Given this list of marker genes Numa1 (NCBI Gene Id 94347), Dhx36, Kalrn (kalirin, RhoGEF kinase), Ncs1, Ago2, Gdpd5, Shank2, Homer2 (homer scaffolding protein 2), Grik5, Camk2b, Lrrk2, Slc4a8, Atp5mc1, Usp8, Ctsl, Snx18, Palm, Rac3, Plec, Avp, Cyp46a1, Epha7, Kcnn3, Aqp1, Epha10, Aif1, Itpr3, Scn8a, Slc7a10, Apc, Atxn1l, Casr, Nlgn3, Prkcg, Cd200l2, Sh3glb1, Htr1b, Fmr1, Capn2, Pclo, Clstn2, Ppp1r9b, Ccr2, Ube2i, Tmem266, Trpc2, Bptf, Scn1a, Samd4, Crh, Syngap1 (synaptic Ras GTPase activating protein 1 homolog (rat)), Snap91, Htr1f, Cfl1, Inpp5j, Mapk8ip2, Bmpr1a, Pnmt, Dbh, Mtmr2, Npy, Adcy4, Sri, Hdac1, Phaf1, Epha3, Scgn, Kif5c, Lmtk2 (lemur tyrosine kinase 2), Jph4, Apod, Kcnma1, Mark3, Hcfc1, Ccl2, Palld (palladin, cytoskeletal associated protein), Dhodh, Ephb2, Ndufs7, Arhgef2, Dab2ip (NCBI Gene Id 98996), Psen2, Snap47, Adnp, Fez1, Ptk2b, Kcnip3, Ptges3, Cd3e, Stx3, Ppargc1a, Prkcz, Ptprn, Calb1, Wdfy3, Rrm1, Rgs14, App, Nts, Ncoa2, Crhr2, Cask, Met, Slc30a1, Arhgap32, Caprin1, Npcd, Lrp8, Trf, Cpne6, Cadm2, Mcrs1, Pde2a, Ndel1, Gper1, Cnn3, Kcnc3, Serpinf1, Esr2, Ddn, Txnrd1, Cacng2, Rbm8a2, Thy1, Washc5, Cck, Shisa7, Erbb3, Bglap (bone gamma carboxyglutamate protein), Ppp1r1b, Ptpn5, Strn4, Dlg3, Fcgr2b, Pard3, Ddc, Homer1, Ldlr, Ireb2, Bmpr2, Ush2a, Strn, Ntf3, Adcy10, Srsf10, Taok2, Glra1 (glycine receptor, alpha 1 subunit), Grik4, Olfm1, Atf4, Sorcs2, Scn11a, Hnrnpk, Gng13, Rplp0, Siah2, Ncdn, Gabra3, Cacna1e, Itgb1, Ank3, Zwint, Sarm1, Kremen1, Rapgef3, Exoc4, Ntrk2, Abitram, Scn3a, Kng1, Rab1a, Ltbp1, Bmpr1b, Snap25, Map2k1, Eif4a3, Cftr, Chrm2, Crhr1, Acsl4, Rac1, Entpd1, Klc1, Src, Plxdc1 (NCBI Gene Id 72324), Mbp, Ppp1r2, Cntnap2, Calcr, Kifap3, Rab8a, Nlgn4l, Ica1, Mob4, Cpeb3, Slc6a6, Dnm3, Th, Rnf112, Cyp19a1, Cald1, Ttll7, Chrm4, Fzd3, Katna1, Hsp90ab1, Epha6 (Eph receptor A6), Dlg4, Psen1, Tmprss11c, Slit2, Arhgef15, Vgf, Prex1, Gabrg1, Smn1, Atp13a2, Chrna4, Cacng7, Hrh3, Txnrd2, Agap2, Sptbn2, Kcnq1, Grin3a, Ppp1r9a, Ckb, Rasgrf1, Hcn4, Calca, Pjvk, Hnrnpab, Kncn, Nr3c1, Tacr3, Ntrk1, Mul1, Enpp1, Sumo1, Syncrip, Hspa5, Fas, Dtnbp1, Kcnc1, Myo5b, Hrh1, Pde10a, Unc5a, Cx3cr1, Pde4b, Tmem151a, Tgfb1, Ptger3, Abi3bp, Fgf13, Prkn, Timp2, Star (steroidogenic acute regulatory protein), Asic2, Sez6 (NCBI Gene Id 20370), Gnaq, Ptger4, Tbx21, Adam11, Ngfr, Dlg1, Flnb, Fzd5, Apoe, Mark1, Rab2a, Ntsr2, Alox5, Npff, Atp7a, Slc32a1 (solute carrier family 32 (GABA vesicular transporter), member 1), Gnat1, Nqo1, Ptchd1, Ppp1ca (protein phosphatase 1 catalytic subunit alpha), Bdnf, Slc6a2, Slc1a2, Comt, Lynx1, Mapk8ip3, Drd4, Grm5, Cacna1c, Stx4a, Kcnk2, Eef1a2, Zdhhc5, Negr1, Cpeb1, Klhl20, Rab3ip, Reg1, Sorl1, Ifngr1 (NCBI Gene Id 15979), Gabre, Sharpin, Apba2, mt-Nd1, Slc9a6, Efna2, Gad2, Resp18, Oprm1, Kpna1, G3bp1, Endog, Il6st, Ptch1, Gnb3, Neo1, Rin1, Dagla, Lrfn3, Gal, Gnas, Kcnq3, Cnga4, Dynlt1f, Kcna2, Adcyap1, N4bp3, Slc17a8, Ptprf, Ada, Adcy8, Slc5a7, Elovl5, Cdk5, Nell2, Prkca, Trak2, Csf1r, Ephb6, Atxn10, Grid2ip, Eif4a3l2, Kcnc4, Chat, Adcy9, Atp2b2, Rheb, Gabbr1, Cd2ap, Trim9, Map1a, Cdc42, Srebf2, Hnrnpu, Myo1d, Rabgef1, Fbxw11, Apob, Baiap2, Gigyf2, Cacng3 (calcium channel, voltage-dependent, gamma subunit 3), Dcp1a, Mink1, Rtn4, Gabra2, Sos1, Smo, Ilk, Add1, Frmpd4, Nrdc, Kcnd2, Ppp1cc, Prkaa2, Kcnh1, Actn1, Adam21, Bsn, Arhgap33, Ermn, Clstn1, Spg11, Itsn1, Fus, Kif1a, Rogdi, Rptor, P2rx3, Tpx2, Gad1, Lrp4, Gipc1, Uhmk1, Abi3, Kcnj11, Fyn, Cacna1f, Cnga2, Tsc22d4, Wdr47, Cpeb4, Osbp2, Enc1, Map2, Epha5 (Eph receptor A5), Snph, Casp6 (caspase 6), Kcnn4, Git1, Canx, Dpysl5, Septin14, Gfra1, Nrsn1, Sptbn4, Asap1, Gpm6a, Ascl1, Srd5a1, Opa1, Upf3b, Slc2a3, Cplx1, Gabra6, Arhgef7, Kirrel1, Cabp1, Syn1, Got2, Tmem50a, Vmn2r1, Serpine2, Cib1, Whrn, Klhl24, S100b, Zpr1, Kcnb1, Creb3, Drp2, 4930544G11Rik, Cacna1a, Ptpro, Picalm, Penk, Map6, Ngf, Camk2n1, Grik2, Map1b, Gabrb1, Pcmt1, Gabra4, Grin3b, Glrx3, Dync1h1, Vstm5, C4b, Malat1, Nppa, Ift52, Vps13a, Kcnj4, Dlgap4, Rit2, Ppp5c, Nf1, Slc9a5, Arg1, Fev, Cnnm4, Ache, Map1lc3b, Gnb1, Vti1b, Chl1, Hdac6, Azin2, Slc38a2, Iqschfp, P2rx2, Kif3b, Mapk8ip1, Hpn, Kif5a, Adgrb1 (NCBI Gene Id 97994), Pvalb, Pias3, Slc8a2, Trpc5, Ppt1, Slc8a3, Ppfia1, Septin4, Ctla2a, Rtn1, Fkbp4, Kndc1, Ctnnd2, Rps6-ps4, Ift20, Sez6l, Kcna4, Ybx1, Ubxn2a, Cacna1d, Shisa9, Evx1, Septin7, Gata3un (Gata3 upstream neighbor), Abhd13, Dynlt1a, Nsg1, Naip1, Lrp1, Igsf9, Lhfpl4, Cfh (NCBI Gene Id 192290), Itga4, Hcn1, Eef2k, Tiam1, Gchfr, Kcna1, Begain, Atp6ap2, Tanc1, Tnk2, P2rx7, L1cam, Anxa5, Ror2, Pebp1, Rgs10, Gnao1, Ccr4, Kcnk1, Pycard, Pdgfb, Htr4, Cacng8, Ncf1, Farp1, Hnrnpa2b1, Pde9a, Adra2a, Trpm2 (NCBI Gene Id 97643), Omp, Cpe, Cobl, Chrna10, Arhgap44, P2rx6, Tgfb2, Hspb1, Htr6, Acan, Pals1, Trpm1, Rtn4rl2 (reticulon 4 receptor-like 2), Fubp3, Gap43, Dnajb1, Hrh4, Htr5b, Prkar2b, Fbxo2, Ptprs, Kif17, Hsp90aa1, Kcnk9, Mrgpra3, Rbfox3, Nin (ninein), Slc38a1, Kcnj14, Dynlt1b, Rangap1, Adcy1, Slc6a1, Naip6, Inpp5f, Txn1, Ephb1, Pdyn, Uri1, Rps6, Pam, Homer3, Adcy2, Cst3, Insr, Nlgn2, Asic1, Snca, Grin2b, Dvl1, Ppp2r1a, Kif2a, Lrp6, Elk1, Slc12a2, Nsf, Cdk5r1, Acvrl1, Bglap2, Vip, Arrb2, Chrm5, Adrb2, Eif5a, Syap1, Kcnc2, Astn1, Clstn3 (calsyntenin 3), Dicer1, Ifng, Amigo1, Mtnr1a, Cntf, Lsm1 (LSM1 homolog, mRNA degradation associated), Abl2, Rtn4rl1, Nectin3, Trim3, Fxr1, Plcb4, Optn, Cnr2, Gopc, Pmm1, Grk3, Grik3, Ret, Grm2, Kcnab1, Cntn2, Klhl17, Unc80, Epha8, Fat3 (NCBI Gene Id 382129), Ckap5, Gabrg3, Arpc2, Btd, Trpm4, Nos1, Erbb2, Brinp3, Adra2c, Ang, Zfp804a, Dner, Rgs11, Dlg2, Glra3, Rtn4r, Ptprz1, Grip1, Pcsk5, Kif3c, Skor1, Kcnd1, Cyp17a1, Mmp3, Psd2, Rack1, Grin1, Kirrel3, Tacr1, Dab1, Gabrb2, Adora3, Sod1, Mlph, Dip2b (NCBI Gene Id 239667), Nr1d1, Trpv1, Pmm2, Mylk2, Zc4h2, Aurka, Crtc1, Ager, Ass1, Gip (NCBI Gene Id 14607), Fabp7, Cd22, Cpne5, Neurog1, Eno2, Igf2bp1, Aatk, Cnga3, Arc, Aplp2, Kcnd3, Usp33, Ophn1, Trpm7, Efhc1, Sv2a, Pde1b, Gpr37, Necab2, Atoh7, Dgki, Ercc8 (NCBI Gene Id 77046), Grk2, Rgs8, Afdn, Rapgef2, Brinp2, Rin3, Nlgn1, Lrp2, Epha4, Nrsn2, Astn2 (astrotactin 2), Slitrk2, Slc12a5, Gabra5, Kcnj2, Ubb, Zdhhc12, Scn1b, Inha, Mdga1, Pnoc, Dpp6, Dlgap2, Igsf9b, Ngb, Flrt1, Hnrnpr, Dip2a, Tmprss5, Cit, Drd2, Htr1a, Kif3a, Cx3cl1, Ctnnb1, Lama2, Rph3a, Inpp5a, Max, Fscn1, Shh, Rbm8a, Kcnip1, Becn1, Cacna1h (calcium channel, voltage-dependent, T type, alpha 1H subunit), Mapt, Dbnl, Nrp1, Slc25a27, Rara, Sfpq, Shank3, Atp1a3, Arrb1, Syndig1, Copa, Pde1a, Dynlt1c, Reln, Htr1d, Bnip3, Sema4f, Klhl14, Ptk2, Cadm1, Tanc2, Rab27a, Rgs12, Anks1b, Gabrg2, Pura, Brs3, Sipa1l1, Gpc1, Synpo, Jam2, Tnf, Hpca, Sh3gl2 (SH3-domain GRB2-like 2), Pgr, Acot7, Esr1, Nmnat3, Kcnn1, P2ry1, Rcvrn, Psmc2, Cyp11a1, Chrm3, Drd1, Aqp11, Ngdn, Efnb2, Glrx, Fzd4, Kcnj12, Mark4, Mgat5, Htr3b, Tmem108, Bag2, Mtor, Grm8, Pum2, Marcks, Rgs7bp, Oprd1, Kng2, Slc3a2, Cygb, Htr3a, Eif4b, Igf1r, Apba1, Slc8a1, Hspa8, Cacng4, Apbb1, Capzb, Cacna1g (NCBI Gene Id 12291), Nectin1 (nectin cell adhesion molecule 1), Pdlim4, Shroom2, Mpl, Prr7, Igf1, C9orf72 (C9orf72, member of C9orf72-SMCR8 complex), Mapk8, Uchl1, Ccn3, Eif4a3l1, Agfg1 (NCBI Gene Id 98611), Wfs1, Apba3, Dmd, Ppp3ca, P2rx4, Slc1a1, Abhd17b, Kcnip4, Tpbg, Shisa6, Csnk1e, Septin11, Mapk1, Pex5l, Zc3h14, Shtn1, Adam10, Napepld, Trak1, Ncam1, Lrit1, Chrna3, Tmprss3, Robo1, Slc18a2, Agrp, Ric3, Gabra1, Ttbk1, Prnp, Crhbp, Shank1, Mt3, Pde1c (phosphodiesterase 1C), Opn4, Polr2m, Tmem222, Gpr179, Myo6, Itga8, Nsg2, Tmem185a, Nucb2, Brinp1, Kif1b, Hcn2 (hyperpolarization-activated, cyclic nucleotide-gated K+ 2), Dlgap3, Grm1, Dyrk1a, Clip2, Glra4, Cpt1c, Cdkl5, Cttnbp2, Hcn3, Gphn, Grm7, Cyp11b2, Wls, Dock10, Lzts3 (NCBI Gene Id 278961), Cnksr2, Mpdz, Adora2a, Map1s, Sema3a, Psd, Grk4, Crcp, Palmd, Cplx2, Magee1, Snx1, Akap12, Zfp385a, Akap9, Ntsr1, Lrrc4, Naip2, Magohb, Tiam2, Asl, Grip2, Ndfip1, Dmwd, Ntf5, Sez6l2, Slc1a3, Rgs7, Kdr, Prss12, Plk3, Kif21b, Glrx5, Vps16, Trhr2, Plk2, Camk2d, Srr, Syt5, Map2k4, Lrit3, Sncb, Cryab, Cttn, Kcnj6, Katnb1, Ckmt1, Lamp1, Gnrh1, Clu, Bace1, Xrn1, Tubb4a, Cd200l1, Ero1a, Strn3, Rpsa, Pcsk2, Calb2 (calbindin 2), Rap1gap, Cyfip1 (NCBI Gene Id 29878), Flna, Crmp1, Oprk1, Gjc2, Myo10, Gabrd, Ighmbp2, Mark2, Kcnip2, Abhd17a, Myh10, Cnih3, Htr7, Bglap3, Cd40, Alcam, Impa1, Lgi1, Shisa8, Tsc2, Piezo2, Stat1, Ptbp2, Pi4k2a, Ulk1, Arf4, Grm3, Gng3, Maf1, Gna12, Myl7, Fxr2, Pten, Cnih2, Bcr, Srcin1, Htr2b, Dixdc1, Erbb4, Trp63, Chrna5, Erc2, Cript, Golga2, Grik1 (glutamate receptor, ionotropic, kainate 1), Neurl1a, Kif1c, Pcdh8, Mme, Hap1, Gria4, Boc, Bin1, Zmynd8, Gdi1, Grid1, Ift57, Rab5a, Samd14, Atp2b1, Pdpk1, Ptpn6, Klhl1, Stau2, Rufy3, Khsrp, Nsmf, Cad, Sdc2, Stmn2, Kcnn2, Slc22a3, Mapk10, Hrh2, Brd1, Zfyve27, Kcne3, Dctn1, Tpgs1 (NCBI Gene Id 216149), Casc3, Smurf1, Tubb3, Tmem100, Il6ra, Lamp5 (lysosomal-associated membrane protein family, member 5), Rps3, Cyba, Prrt2, Prph, Gria3, Glul, Ccr1, Tenm2, Ucn, Lypd6, Ghrh, Myo5a, Frmd7, Anxa3, Numb, Grm4, Gsk3b, Dtnb (NCBI Gene Id 13528), Top1, Rhoa, Nrxn1, Nrg1, Nefm, Itpka, Abhd12, Ghr, Cntnap4, Slc4a10, Nptn, Grid2, Akap5, Itpr1, Sst, Nrgn, Pcsk1, Dennd1a, Pafah1b1, Grm6, Hip1r, Chrna7, Ctnnd1, Maob, Chrm1, Gria2 (NCBI Gene Id 14800), Glrx2, Dscam, Als2, Espn, Pard6a (par-6 family cell polarity regulator alpha), Snx14, Flot2, Glrb, Htr2c, Trpm5, Syt4, Lrrc7, Slc6a3 (solute carrier family 6 (neurotransmitter transporter, dopamine), member 3), Htt, Lnpep, Mapk9, Grin2a, Arfgef2, Kif21a (NCBI Gene Id 16564), Dbn1, Ccng1, Atp1a2, Tnn, Cntnap3, Hdc, Htr5a, Txn2, Ppfia2, Casp4, Srd5a2, Sorbs2 (NCBI Gene Id 77324), Srgap2, Ar, Pabpc1, Cybb, Pak1, Tgfb3, Unc5c, Syt7, Pawr, Slc38a7, Ubxn1, Kcnb2, Il1rapl1, Itga1, Gnb5, Kiss1, Lmtk3, Mirc35hg, Abhd17c, Cdh9 (NCBI Gene Id 12565), Vps35, Myo1a, Gria1, Naip5, Sirt2, Rpl28, Mast1, Adora1, Stau1, Abl1, Abi2, Nefh, Ephb3, Agtr1a, Gnai2, Rbm3, Pgrmc1, Casp3, Gripap1, Mpp2, Atcay, Ptprk, Cacna1b, Sncg, Pick1, Elfn1, C4a, Ykt6, Clcn2, Acad9, Cnnm1 (NCBI Gene Id 83674), Slc31a1, Syt11, Prkaa1, Amfr, Htr2a, Fbxo31, Magi2, Elavl4, Rab17, Cd200, Cacna1s, Epm2a, Rapgef4 (NCBI Gene Id 71744), Abr, Dpysl2, Phax, Drd5, Lzts1, Camk2a, Tnfrsf1b, Dcx, Hmcn2, Pde11a, Bcan, Tac1, Trappc4, Luzp1, Nfasc, Slc1a4, S100a5, Nap1l4, Gabarapl1, Serpini1, Sgce, Sort1, Gnaz, Vti1a, Lpar1, Fchsd1, Ogt, here is a description of the gene set: The region of a neuron that includes the cell body (cell soma) and dendrite(s), but excludes the axon. studied in species Mus musculus Mouse Gene Set: GOCC_SOMATODENDRITIC_COMPARTMENT